Given this list of marker genes ATP2B4, CRTC3, CHGA, DRD1, GNAS, ADRB3, DRD5, ARRDC3, ADCY9, GPR101, GNAI2, PLN, RAPGEF2, PDE4B, ADRA2A (NCBI Gene Id 92480), ADRA1D, ADRA1B, ADRB2 (adrenoceptor beta 2), ADRA1A, ADRB1, here is a description of the gene set: Human Gene Set: GOBP_ADENYLATE_CYCLASE_ACTIVATING_ADRENERGIC_RECEPTOR_SIGNALING_PATHWAY An adenylate cyclase-activating G protein-coupled receptor signaling pathway initiated by a ligand binding to an adrenergic receptor on the surface of the target cell, and ending with the regulation of a downstream cellular process. studied in species Homo sapiens